The following is a description of a gene set: from publication Dorsey JF, Cunnick JM, Mane SM, Wu J (PMID 11830491) studied in species Homo sapiens Human Gene Set: DORSEY_GAB2_TARGETS In the blast crisis phase of chronic myelogenous leukemia (CML), Bcr-Abl(+) myeloblasts fail to undergo terminal maturation. The extracellular signal-regulated kinase (Erk) mitogen-activated protein (MAP) kinase has been shown to mediate terminal differentiation of myeloid cells. Interestingly, Bcr-Abl(+) CML cell lines established from blast crisis were found to have low Erk MAP kinase activity. In this study, we analyzed the role of the Gab2 docking protein in regulation of the Erk MAP kinase in Bcr-Abl(+) K562 human CML cells. Overexpression of Gab2 in K562 cells resulted in transcriptional activation of the c-fos serum response element (SRE) promoter, whereas overexpression of SHP2, Grb2, and CrkL had no effect. Activation of the c-fos SRE transcriptional activity by Gab2 required tyrosine 604, which is a SHP2 docking site on Gab2, and the SHP2 tyrosine phosphatase activity. Elk1, c-Jun, and CHOP trans-reporting assays indicated that overexpression of Gab2 selectively activated the Erk2-Elk1 signaling pathway. To determine cellular consequences of elevating the Gab2 level in K562 cells, stable cell lines for doxycycline-inducible expression of the wild-type Gab2 (Gab2WT) and an SHP2-binding defective Gab2 (Gab2Tyr604Phe) were established. Analysis of these cell lines indicated that induction of Gab2WT expression, but not Gab2Tyr604Phe expression, led to Erk activation, growth arrest, cell spreading, and enlargement; expression of megakaryocyte/platelet lineage-specific integrins alphaIIb/beta3 (CD41/CD61); and upregulation of RNA for megakaryocyte/platelet proteins. All of these changes are characteristics of megakaryocytic differentiation. Together, these results reveal Gab2 as a limiting signaling component for Erk MAP kinase activation and terminal differentiation of K562 CML cells. Genes up-regulated by expression of GAB2 in K562 cells (chronic myeloid leukemia (CML) cell line with p210 BCR-ABL)., and this is the list of marker genes: REN, TNFRSF9, CD44, ARHGAP25, ACVR1, PHLDA2, COL1A1, IL13RA2, ITGA2B, GK, HSD17B1, GRIK1, PRSS3, AKAP12, CCRL2, SMAD7, GNG11, TFPI2, SPARC, SERPINE1, CD69, PRSS1, DUSP5, CRYAB, STC1, ATP1B1, COL6A3, GSN, THBS1, ITGB3